The following is a description of a gene set: Cytokines mediate cell-cell communication in the immune system and represent important therapeutic targets. A myriad of studies have highlighted their central role in immune function, yet we lack a global view of the cellular responses of each immune cell type to each cytokine. To address this gap, the authors created the Immune Dictionary, a compendium of single-cell transcriptomic profiles of more than 17 immune cell types in response to each of 86 cytokines (>1,400 cytokine-cell type combinations) in mouse lymph nodes in vivo. A cytokine-centric view of the dictionary revealed that most cytokines induce highly cell-type-specific responses. For example, the inflammatory cytokine interleukin-1β induces distinct gene programmes in almost every cell type. A cell-type-centric view of the dictionary identified more than 66 cytokine-driven cellular polarization states across immune cell types, including previously uncharacterized states such as an interleukin-18-induced polyfunctional natural killer cell state. species: Mus musculus from publication Cui A, Huang T, Li S, Ma A, Pérez JL, Sander C, Keskin DB, Wu CJ, Fraenkel E, Hacohen N (PMID 38057668) Mouse Gene Set: CUI_NEUTROPHIL_IFNA1_RESPONSE_UP Genes positively differentially expressed in cell type: Neutrophil upon treatment with cytokine: IFN-α1 in mouse lymph nodes in vivo., and this is the list of marker genes: Ifit1bl1, Stat2, Cmpk2, Ifi47, Ifi204 (interferon activated gene 204), Slfn5, Isg15, Ifit3b, Parp14, Sp100, Cxcl10, Pnp, Gbp2, Plac8, Ifit2 (interferon-induced protein with tetratricopeptide repeats 2), Trim30c, Gbp3 (NCBI Gene Id 99898), Ddx60, Psmb8, Slfn4, Socs1, H2-T23, Gbp5, Irf7, Ctss, Trim30a, Herc6, Ifit1, Oasl1, Psmb9, Ifitm3, Nt5c3, Oas3, Ifi211, Fcgr1, Ifi209, Eif2ak2, Isg20, Xaf1, Acer3, Usp18, Rsad2, Ifit3, Tor3a, Znfx1, Sp110